Given this list of marker genes Cyp2b10, Cyp2b23, Cyp2b19, Cyp3a59 (NCBI Gene Id 100044462), Cyp2b13, Cyp3a57, Cyp3a25, Cyp2b9, here is a description of the gene set: Catalysis of the reaction: O2 + reduced + testosterone = 16alpha,17beta-dihydroxyandrost-4-en-3-one + H+ + H2O + oxidized. Mouse Gene Set: GOMF_TESTOSTERONE_16_ALPHA_HYDROXYLASE_ACTIVITY species: Mus musculus